Given this list of marker genes RHOV, SMIM3, EFNA3, POU1F1, POM121L10P, CXXC5, DDO, TEX46, DUOX1, ZNF225-AS1, RIT2, MROH2B, LCN8, OR52D1, ADAMTS8, MARK1, PLD4, UNK, PRX (NCBI Gene Id 57716), CRYGN, SLC10A2, NEU2, ASPA, LMOD3, FSTL5, CCL2, LDHAL6A, EEF1E1, PARVA, TREX2, SMTN, FZD10-AS1, SLC18A3, PCDHA9, GABRB1, MTA2, TRGV5, LRTM2, GALR2, TNFRSF19, ORMDL3, GADD45GIP1 (GADD45G interacting protein 1), ENSG00000277182, CDIP1, OR8G1, UMAD1, ATP8B1-AS1, HSD11B1L, MAMDC2-AS1, LINC00276, PCOLCE2, SPRYD4, FGFR3, LAGE3P1, NIM1K, ABCA12, FARS2, FLG, PITX2, CST9L, EHF, UBE2D3, PPP1R1C, CCN6, MMP21, WASIR2, GAD1, EMC9, CDH12, NQO1, LINC01904, SLC51A, ECSIT, NMRAL2P, FAM131C (NCBI Gene Id 348487), FMO6P, ACVRL1, PDS5B, SLC9A3, CTXN1, ROMO1, LIMS2, OR7E19P, INSM1, CLDN3, DDX19B, ULBP1, CINP, NXNL2, EPHX3, MYOT, ASIC3, SYDE1, APEX2, SNRPC, HSPD1, POLD4, CRIP1, MIR663AHG, TIGD6, GALNT5, ZCCHC9, ARHGEF28, OR1A2, RNF150, TLL1, LINC00102, ENSG00000286546, ABCB8, LINC02877, MLH1, RNF25, HMCN1, CREB3L3, TRPV6, DDR1-DT, FUT1, CNOT10, PHB1, FGD5-AS1, MESP1, CDKL5, GRM4, NOTUM, OR2B6, AIRE, DKK4, HOXA-AS2, NXNL1, PRR29 (NCBI Gene Id 92340), CTNNA2, ANGPTL1, RUNDC3A, RPL23A, KRTAP19-3, DRD5, GJD4, SERPINE1, TSTD2 (NCBI Gene Id 158427), LINC00930, CDC37, DOCK6, DEFB127, C19orf48P, FGF8, CHKB, RIPPLY3 (ripply transcriptional repressor 3), PEBP4, HYAL6P, TMEM74, BPIFB1, TDP2, LIG4, B4GALT2, GALR1, LINC01226, CDC40, AHDC1, IGLV4-60, FAM185A, SLC35F5, SYTL5, GJA8, DPEP1, LINC02135, NUP155, FAM162B, HES1, KCNJ4, NEDD9 (NCBI Gene Id 4739), HDAC6, CYP11A1, KHDRBS2, C15orf32, PROX2, ARFGAP2, HEXA-AS1 (HEXA antisense RNA 1), F3, ZNF497, CFC1, PAK2, ERLEC1P1, DOK4, JARID2, ADAM30, ZNF480, TRPV5, TAFA5, ADARB2, OR8B8, RPS14, here is a description of the gene set: Human Gene Set: GSE29614_CTRL_VS_DAY3_TIV_FLU_VACCINE_PBMC_UP Genes up-regulated in comparison of peripheral blood mononuclear cells (PBMC) from TIV influenza vaccinee pre-vaccination versus those from day 3 post-vaccination. Systems vaccinology has emerged as an interdisciplinary field that combines systems wide measurements and network and predictive modeling applied to vaccinology. Here we used the systems vaccinology approach to study the molecular mechanisms underlying the innate responses to the trivalent inactivated influenza (TIV) and live attenuated influenza (LAIV) vaccination in humans, and to identify early gene signatures that predict the magnitude of the antibody responses to influenza vaccination. from publication Nakaya HI, Wrammert J, Lee EK, Racioppi L, Marie-Kunze S, Haining WN, Means AR, Kasturi SP, Khan N, Li GM, McCausland M, Kanchan V, Kokko KE, Li S, Elbein R, Mehta AK, Aderem A, Subbarao K, Ahmed R, Pulendran B (PMID 21743478) species: Homo sapiens